The following is a description of a gene set: Genes up-regulated in CD4 T conv: control versus over-expression of IKZF2. from publication Fu W, Ergun A, Lu T, Hill JA, Haxhinasto S, Fassett MS, Gazit R, Adoro S, Glimcher L, Chan S, Kastner P, Rossi D, Collins JJ, Mathis D, Benoist C (PMID 22961053) Human Gene Set: GSE40274_CTRL_VS_HELIOS_TRANSDUCED_ACTIVATED_CD4_TCELL_UP studied in species Homo sapiens The transcription factor FoxP3 partakes dominantly in the specification and function of FoxP3+ CD4+ T regulatory cells (Tregs), but is neither strictly necessary nor sufficient to determine the characteristic Treg transcriptional signature. Computational network inference and experimental testing assessed the contribution of several other transcription factors (TFs). Enforced expression of Helios or Xbp1 elicited specific signatures, but Eos, Irf4, Satb1, Lef1 and Gata1 elicited exactly the same outcome, synergizing with FoxP3 to activate most of the Treg signature, including key TFs, and enhancing FoxP3 occupancy at its genomic targets. Conversely, the Treg signature was robust to inactivation of any single cofactor. A redundant genetic switch thus locks-in the Treg phenotype, a model which accounts for several aspects of Treg physiology, differentiation and stability., and this is the list of marker genes: AURKA, IQGAP2, AMPD3, ST3GAL1, TUG1, TMEM71 (NCBI Gene Id 137835), RASGRP2, AQP11, HIP1, MAN2A1 (NCBI Gene Id 4124), SIRT6, ABHD12, EXOC6, RASSF4, UBAC2 (UBA domain containing 2), TMX3, DEF8, STX2, ST3GAL4, KMO, ASAH1, KMT5C, LCN8, PRKD2, PIK3CG, LGALS1, NUDT7, PLXNA1, BPTF, PSD4, SPOP, ATP1B2, RFC2, MARVELD1, DAB2IP, LPAR5, ELAC1, CEBPA, HDAC10, DEF6, CACNA1E, MGST1, GBP5, H2BC26, MATK, PPP1R21, FCGR1A, NCOA7, CLNK, CARNS1 (NCBI Gene Id 57571), ANO6 (NCBI Gene Id 196527), ARHGEF18, ANXA6, GPR155, ALOX5AP, CD300C, SDCCAG8, TMEM134, HP, STAT2, FAM168A, SPIRE1, GDF11, MSTN, SKA1, ELMO2, CDK20, RASSF3, FBXL8, KAT2B, KIF21B, GDI1, PDE5A (NCBI Gene Id 8654), PRTN3, KIF9, IL27RA, MTARC2, GIMAP3P, XDH, RAPGEF4, AP1S3 (NCBI Gene Id 130340), MYO18A, TNFAIP8, PHKA1, ANKRD44, SLC25A23, PPP1R9B, PRKDC, MCTP2, KCNA2 (potassium voltage-gated channel subfamily A member 2), IDH2 (isocitrate dehydrogenase (NADP(+)) 2), CELF4, ADAM15, PTPRE, PTPN6, RCSD1, KHK, RPUSD1, PSAP, INVS, PHACTR2, CLASP1, CERS4, SLC25A53, SHLD2, RGS14, SLC46A3, CREBBP, EHHADH, SORCS2, RIPOR2, DPM3, EIF1B, TSEN34, TKTL1, TRAPPC2 (NCBI Gene Id 6399), HEMGN, H2AZ1, CSF3R, XKRX, GRHPR, DECR2, CPOX, ALPK1, KIZ, MOB3B, PPM1H, LIPA, FCHSD2, SULF2, MOB3A, ITGA2, PLA2G4A, PLA2G7, IKBIP, GAS2L1, ACKR2, POC1A, ST6GAL1, SLC14A1, ADRB2, CD99L2, SERINC5, TRIM21, IL10RA, ARSK, EVI5L, SRPK3, RP9, TATDN3, ESCO2, SLC35A5 (NCBI Gene Id 55032), AGAP1, BCL2L14, EMID1, NFAM1, KYNU, THRB, TSPAN17, NDUFS2, KLHL14, ST3GAL3, ECH1, PADI2, TBC1D1, APOOL